Given this list of marker genes MAP2K5, CDX1, CRABP2, DUOXA2, EDN1, SRSF3, MYH1, TNFSF10, UCN, BZW2, MT3, ASB4, BACH1 (NCBI Gene Id 571), IL17A, RHOBTB1, RPS3, OLIG2, LHX6, RGS1, LTA, GBE1, KRT10, MITF, JARID2, MYH4 (NCBI Gene Id 4622), CILP, HTN1, CRYBA1, TTC17, ELAVL3, SERPINH1, ESRRG, PRDM12, PMEPA1, SOX3, ADAMTS15, TUBA4B, H2BC1, NDP, AQP1, TPM1, TCF7, FGF19, DDX3X, NPTX1, MAT2A, H1-2, H1-1, BHLHE22, NR4A1, CYP1A2, CEP95, RGS4, KRT24, ADAMTS1, SMYD1, SLC2A4, PURA, HOXD4, KRT25, GARRE1, KRTAP12-3, PTP4A1, HBZ, S100A4, SPRR1B, MMP10, KLHL40, DIO2, CCL7, TMPO, RHOA, MLIP, NASP, HOXD9, AMPD1, CIPC, GRID2, RASGRP3, CEMIP (NCBI Gene Id 57214), BPIFA1, EEF1A1, KRT1, CX3CL1, PPARG, HOXA10, KRTAP11-1, KRT26, NEFH, ASB16 (NCBI Gene Id 92591), WDR82, ACTA1, KRTAP4-2, H1-6, COL13A1, ARHGEF2 (Rho/Rac guanine nucleotide exchange factor 2), ADAMTSL2, PNMA1, IL10, GH1, PANK1, CKM, EGR2, GCH1, ERRFI1, STAC, H2AZ1, KRTAP12-4, MIP, RUNX2, LEAP2, NEUROG2, RLN3, DIRAS1, DKK2, POMC, WSB2, CSH2, H2AC1, TRDN, NNT, ARHGEF38, CELF4, HDLBP, FSHB, DES, HOXA11, KLF2, FOXP3, TTR, MYH3, EEF2, SCN8A, TCTA, MSTN, GSC, KRTAP4-1, DDX5, PCDH8, CA2, CSHL1, FGF4, H3-3B, LCE5A, MT4, MID1, MYCT1, GRIN2B, CSNK1E, CXCR4, TSC1, ATXN7L1, ATOH1, HOXC4, CNN1, HNRNPA0, TSPAN13, SUPT4H1, SCAMP3, IL22, CBLN4, ECE2, C2CD4A, EIF4A2, KRTAP6-2, TNFRSF17, SLC34A1, PRDM10, TMEM117, PDYN, EGFL7, GPRC5D, KIRREL2 (NCBI Gene Id 84063), NEFM, MRPS18B, MYF6, KRTAP20-2, PLAG1, CTNNA3, POU3F4, DKK1, ANKMY2, TUBA4A, ABCA1, CFL2, CARF, SCHIP1, NDRG2, BNIP3 (NCBI Gene Id 664), PATZ1, HOXC5, RPL10, KRTAP9-2, TSC22D1, CSH1, NPPA, ITPR1, DYRK2, KRT2, GH2, OLIG3, RBP2, TGM3, MYOZ2, PPP1R10, NHS, CDC25B, ZFP36L2, CKB, NPAS4, SELENOP, LIF, FGF20, SIM1, ZC3H10, H1-5, COL10A1, CLCN1, NANOS1, STC1, ABLIM1, TSHB (NCBI Gene Id 7252), SLC25A4, DMPK, BMI1, NR0B2, SLC50A1, SOSTDC1, HSPB2, FGF16, H3-4, GTF2A1, DUOX2, NOG, COL1A1, CRYAB, ANGPT4, CCL5, PDLIM7, TNNC2, KRTAP21-1, FGFRL1, MMP20, KRTAP4-4, IL11, SOX5, XK, TSC22D3, KRT77, HBEGF, PRDX1, PABPC4, CYB561D1, AGT, GADD45G, ADAM11, here is a description of the gene set: Human Gene Set: TATA_01 Genes having at least one occurrence of the motif STATAAAWRNNNNNN in the regions spanning 4 kb centered on their transcription starting sites. This matches the TAF, TATA transcription factor binding site V$TATA_01 (v7.4 TRANSFAC). species: Homo sapiens